Given this list of marker genes Cadm3, Nectin4, Nectin2, here is a description of the gene set: This event has been computationally inferred from an event that has been demonstrated in another species.<p>The inference is based on the homology mapping from PANTHER. Briefly, reactions for which all involved PhysicalEntities (in input, output and catalyst) have a mapped orthologue/paralogue (for complexes at least 75% of components must have a mapping) are inferred to the other species. studied in species Mus musculus electronically inferred by orthology from the curated human pathway part of: Adherens junctions interactions Reactome Pathway: Nectin/Necl  trans heterodimerization